The following is a description of a gene set: PTK6 Regulates Proteins Involved in RNA Processing Mouse Gene Set: REACTOME_PTK6_REGULATES_PROTEINS_INVOLVED_IN_RNA_PROCESSING species: Mus musculus, and this is the list of marker genes: Sfpq, Ptk6, Khdrbs2, Khdrbs1, Khdrbs3